Given this list of marker genes SOX10, MTMR2, PRX, NEFL, MPZ, EGR2, SBF1, PMP22, SBF2, here is a description of the gene set: species: Homo sapiens Increased amount of peripheral myelination. Peripheral hypermyelination Human Gene Set: HP_PERIPHERAL_HYPERMYELINATION